The following is a description of a gene set: species: Homo sapiens The portion of the microtubule cytoskeleton that lies just beneath the plasma membrane. Human Gene Set: GOCC_CORTICAL_MICROTUBULE_CYTOSKELETON, and this is the list of marker genes: CLASP1, CLASP2, MAPRE1, NUMA1, PDE4DIP